Given this list of marker genes CD151, SREBF2, PTGR1, CDC20, CCNB1, SLC3A2 (NCBI Gene Id 6520), XRCC6, MYH9, IL7R, EFNB1, SLC16A1, CDKN3, ZBED3, FCGR2A, RAG2, GFRA1, GFPT1, KMT2B, RELN, AQP4, GPAM, HLA-B, PRM1, SMARCA4, PTPRG, AP4B1, SELENOP, RAG1, RAB6B, EZH2, GZMM, NUPR2, IL6ST, DNMT3A, GLRX, PLA2G4F, RAB36, FGL2, here is a description of the gene set: from publication Hoffmann R, Seidl T, Neeb M, Rolink A, Melchers F (PMID 11779835) Gene expression profiles of five consecutive stages of mouse B cell development were generated with high-density oligonucleotide arrays from as few as 2 x 10(4) ex vivo isolated and flow-cytometrically purified cells. Between 2.8% and 6.8% of all genes change on differentiation from one cellular stage to the next by at least twofold. The entire pathway involves differential expression of 10.7% of all genes. Previously known expression patterns of genes (like surrogate light chain, RAG-1/2, MHC class II, mel-14 antigen) are confirmed. The gene expression patterns of the proliferating pre-BI and large pre-BII cells on the one hand, and the resting immature and mature B cells on the other hand, are most similar to each other. Small pre-BII cells display a pattern that is transitional between these two groups. Most of the genes expressed in early precursors are involved in general processes, like protein folding or cell cycle regulation, whereas more mature precursors express genes involved in more specific molecular programs (cell surface receptors, secreted factors, and adhesion molecules, among others). Between 19 and genes share a given expression pattern. Combining knowledge about gene function and expression pattern allows identification of novel candidate genes potentially involved in self-maintenance of pre-BI cells, allelic exclusion and pre-B cell receptor signaling in large pre BII cells, cell-cycle arrest of small pre-BII cells, propensity toward apoptosis or anergization in immature B cells, propensity toward cell division and activation in mature B cells, and stage-specific interactions with stromal cells in the bone marrow. Human Gene Set: HOFFMANN_SMALL_PRE_BII_TO_IMMATURE_B_LYMPHOCYTE_DN Genes down-regulated during differentiation from small pre-BII to immature B lymphocyte. species: Mus musculus